The following is a description of a gene set: species: Homo sapiens Human Gene Set: GOBP_SIGNAL_TRANSDUCTION_INVOLVED_IN_REGULATION_OF_GENE_EXPRESSION Any process that modulates the frequency, rate or extent of gene expression as a consequence of a process in which a signal is released and/or conveyed from one location to another., and this is the list of marker genes: SMAD3, P2RY1, MSX2, PAX6, TBX6, NEUROD1, FGF5, MESP1, PLA2G10, EDN1, TRAF2 (TNF receptor associated factor 2), IKBKB, HNF4A, PDGFRA, IRF3, GSC, TRAF3IP2, MSX1, NFKB1, EPCAM, SOX17, PARP1, TRAF5, DAND5, FGF8, SRSF1, NFKBIA, CER1, RELA